Given this list of marker genes CYP39A1, NR1H4, CYP2A13 (cytochrome P450 family 2 subfamily A member 13), CYP21A2, ADH7, ARNT, CYP24A1, CYP2S1, CYP4F22, CYP1B1, CYP27B1, FDX2, CYP4V2, CYP26B1 (NCBI Gene Id 56603), RXRA, NCOA2, CYP11B1, FDXR, POR, CYP2C18, CYP2J2, CYP46A1, AHRR, CYP2C8, CYP1A1, CYP2F1, CYP2A7, CYP2R1, CYP2C19, CYP2B6, CYP2W1, CYP2E1, CYP4F3, CYP19A1, CYP4A22, CYP4F12 (NCBI Gene Id 66002), CYP11A1, PTGIS, ARNT2, CYP7B1, CYP3A7, CYP4B1, CYP2C9, CYP4F8, CYP27A1, POMC, CYP1A2, CYP26C1, CYP7A1, CYP3A5, CYP26A1, TBXAS1, AHR, CYP2U1, CYP51A1, NCOA1, CYP3A43, CYP4A11, CYP2D6, FDX1, CYP2A6, CYP4F11, CYP8B1, CYP3A4, CYP11B2, CYP4F2, here is a description of the gene set: <p>The P450 isozyme system is the major phase 1 biotransforming system in man, accounting for more than 90% of drug biotransformations. This system has huge catalytic versatility and a broad substrate specificity, acting upon xenobiotica and endogenous compounds. It is also called the mixed-function oxidase system, the P450 monooxygenases and the heme-thiolate protein system. All P450 enzymes are a group of <i><b>heme-containing isozymes</b></i> which are located on the membrane of the smooth endoplasmic reticulum. They can be found in all tissues of the human body but are most concentrated in the liver. The name "cytochrome P450" (CYP) is derived from the spectral absorbance maximum at 450nm when carbon monoxide binds to CYP in its reduced (ferrous, Fe<sup>2+</sup>) state. The basic reaction catalyzed by CYP is <i><b>mono-oxygenation</b></i>, that is the transfer of one oxygen atom from molecular oxygen to a substrate. The other oxygen atom is reduced to water during the reaction with the equivalents coming from the cofactor NADPH. The basic reaction is;</p><b><p align=center> RH (substrate) + O<sub>2</sub> + NADPH + H<sup>+</sup> = ROH (product) + H<sub>2</sub>O + NADP<sup>+</sup></p></b><p>The end results of this reaction can be (N-)hydroxylation, epoxidation, heteroatom (N-, S-) oxygenation, heteroatom (N-, S-, O-) dealkylation, ester cleavage, isomerization, dehydrogenation, replacement by oxygen or even reduction under anaerobic conditions.</p><p>The metabolites produced from these reactions can either be mere intermediates which have relatively little reactivity towards cellular sysytems and are readily conjugated, or, they can be disruptive to cellular systems. Indeed, inert compounds need to be prepared for conjugation and thus the formation of potentially reactive metabolites is in most cases unavoidable.</p><p>There are 57 human CYPs (in 18 families and 42 subfamilies), mostly concentrated in the endoplasmic reticulum of liver cells although many tissues have them to some extent (Nelson DR et al, 2004). CYPs are grouped into 14 families according to their sequence similarity. Generally, enzymes in the same family share 40% sequence similarity and 55% within a subfamily. Nomenclature of P450s is as follows. CYP (to represent cytochrome P450 superfamily), followed by an arabic number for the family, a capital letter for the subfamily and finally a second arabic number to denote the isoenzyme. An example is CYP1A1 which is the first enzyme in subfamily A of cytochrome P450 family 1.</p><p>The majority of the enzymes are present in the CYP1-4 families. CYP1-3 are primarily concerned with xenobiotic biotransformation whereas the other CYPs deal primarily with endogenous compounds. The CYP section is structured by the typical substrate they act upon. Of the 57 human CYPs, 7 encode mitochondrial enzymes, all involved in sterol biosynthesis. Of the remaining 50 microsomal enzymes, 20 act upon endogenous compounds, 15 on xenobiotics and 15 are the so-called "orphan enzymes" with no substrate identified.</p><p>The P450 catalytic cycle <i>(picture)</i> shows the steps involved when a substrate binds to the enzyme.</p><p><font color=red>(1)</font> The normal state of a P450 with the iron in its ferric state.</p><p><font color=red>(2)</font> The substrate binds to the enzyme.</p><p><font color=red>(3)</font> The enzyme is reduced to the ferrous state by the addition of an electron from NADPH cytochrome P450 reductase. The bound substrate facilitates this process.</p><p><font color=red>(4,5)</font> Molecular oxygen binds and forms an Fe<sup>2+</sup>OOH complex with the addition of a proton and a second donation of an electron from either NADPH cytochrome P450 reductase or cytochrome b5. A second proton cleaves the Fe<sup>2+</sup>OOH complex to form water.</p><p><font color=red>(6)</font> An unstable<sup>3+</sup> complex donates its oxygen to the substrate <font color=red>(7)</font>. The oxidised substrate is released and the enzyme returns to its initial state <font color=red>(1)</font>.</p> Reactome Pathway: Cytochrome P450 - arranged by substrate type part of: Phase I - Functionalization of compounds studied in species Homo sapiens